The following is a description of a gene set: Genes whose promoters are bound by FOXP3 based an a ChIP-chip analysis. Mouse Gene Set: ZHENG_BOUND_BY_FOXP3 from publication Zheng Y, Josefowicz SZ, Kas A, Chu TT, Gavin MA, Rudensky AY (PMID 17237761) Transcription factor Foxp3 (forkhead box P3), restricted in its expression to a specialized regulatory CD4+ T-cell subset (T(R)) with a dedicated suppressor function, controls T(R) lineage development. In humans and mice, Foxp3 deficiency results in a paucity of T(R) cells and a fatal breach in immunological tolerance, causing highly aggressive multi-organ autoimmune pathology. Here, through genome-wide analysis combining chromatin immunoprecipitation with mouse genome tiling array profiling, we identify Foxp3 binding regions for approximately genes and for an intergenically encoded microRNA. We find that a large number of Foxp3-bound genes are up- or downregulated in Foxp3+ T cells, suggesting that Foxp3 acts as both a transcriptional activator and repressor. Foxp3-mediated regulation unique to the thymus affects, among others, genes encoding nuclear factors that control gene expression and chromatin remodelling. In contrast, Foxp3 target genes shared by the thymic and peripheral T(R) cells encode primarily plasma membrane proteins, as well as cell signalling proteins. Together, our studies suggest that distinct transcriptional sub-programmes implemented by Foxp3 establish T(R) lineage during differentiation and its proliferative and functional competence in the periphery. studied in species Mus musculus, and this is the list of marker genes: Kbtbd11, Psma1 (NCBI Gene Id 26440), Itpr2, Pgbd1, Actr3, 4930579G24Rik (RIKEN cDNA 4930579G24 gene), Rb1, Stat4, Rrm2, Nrip1, Rasa3, Psmd4, Cd44, St8sia4, Phxr4, Knl1, Llph, Pvt1, Pias2, Ptk2b, Zap70, Zfp874b, Syne2, Trib2, Znrf1, Zfp608, Usp6nl, Ms4a6c, Gm10688, Reep3, Cd226, Sdr16c5, Oprm1, Slc35b3, Arhgap25, Fermt1, Kdm3a, Ptger2, Rcsd1, Dusp6, Aggf1, Gata3, Rbl2, Sesn1, Gprin3, Vgll4, Btla, Arhgef3, Parp11, Hexim1, Wdr37, Gabrg1, Akap13, Mdm2, Ldlrad4, Bend6, Wdr45, Add3, Fam169b, D16Ertd472e (NCBI Gene Id 69342), Lars1, Klf3, Cnot6l, Eci2, Arl6, Churc1, Prkcq, Ssh2, Ptpn22, Lrch1, Etnk1, Nipbl, Ibtk, Mbnl1, Cnga1, Bcl6, Zfp36l2, Poli, Hk3, Rab8b, Enpp1, Gdi2, Gpd2, Pde7a, Map4k4, Hbs1l, Tlk1, Impa1, Zfp217, Zdhhc20 (zinc finger, DHHC domain containing 20), Mgat5, Ppp3cc, Tra2b (transformer 2 beta), Cast, Elf1, Cd96, Malt1, Samhd1, Slc23a2, St6gal1, Tmsb4x, Smap2, Man1a2 (NCBI Gene Id 99756), Rapgef2, 9330154K18Rik, Tbccd1, Zfp560, ENSMUSG00000122616, Tmco1, Slc35b4, Tox, Lrrc8c, Cep97, Ifi208, Phtf2 (putative homeodomain transcription factor 2), Osbpl8, Ablim1, Sell, Agpat5, Tmem252, Cdc42se2, Corin, Tgfbr2, Zfp715, Fam91a1, Satb1, Utrn, Atp8a2, Rad51c, Prdm1, Fasl, Wdr35, Taf8, St6galnac5, Cadps, Trav3-3, Rpl37, Rp9, Rap1a, Rfx3, ENSMUSG00000134755, Ankrd44, Cd200r1, P4ha1, Cd53, Gimap6, Tec, Scml4, Camk4, Cd69, Tg, Shtn1, Cdk19, Chd2, Ifngr1, Klf2, Clca1, Traf3ip3, Nfkbiz, Atp6-ps, Lrig1, Zc3h12d, Nsmce1, Adss2, Nsmaf, Frs2, Eps15l1, Hif1a, Agps, B3gnt2, Arid5b, Amph, Ptger4, Itga6, Zfp91, Rras2, Bzw2, Stk17b, Cx3cr1, Tmem67, Fyn, Flt3, Grk6, Gldn, 1700111E14Rik (RIKEN cDNA 1700111E14 gene), Ggta1, Abt1, Pag1, Trat1, Mrs2, E2f6, Apbb1ip, Slamf6, Map3k1, Gm10744, Sptbn1, Trp53inp1 (NCBI Gene Id 72576), Leprotl1, Timm8a2, S1pr1, Vcpkmt, Amot, Tnfsf11, Xcl1, Prrg4, Ubac2, Pym1, Ms4a4d, Morrbid, Gbp6, Pgap1, Glcci1, Hivep2, Ube2h, Il2ra, Samsn1, Btbd10, Ndc80, Trim27, Cnot2, Frmd4b, Ttc5, A130050O07Rik, Il10rb, Sp100, Vopp1, Rdm1, Nr4a2, Esyt2, Utp3, Klf6, Sumf1, Cadm3, Rgs13, Trim12a, Muc20, Dipk1a, Rnf125, Ankrd11, Usp3, Xxylt1, Gm6899, Axl, Trib1, Herpud2 (NCBI Gene Id 80517), Cr1l, Slc30a7, Cdkn1b, Rhoh, Lta4h, Ulk4, Rabgap1l (RAB GTPase activating protein 1-like), Tube1, mt-Nd4l, Akr1d1, AA467197, Exoc6b, Hjv, Prag1, 9930111J21Rik2, Zfp51, Fas, Gpr18 (NCBI Gene Id 263515), Ttc39b, Cdh10, Mllt3, Scn8a, Gpr65, Fam107b, Man1a, Zc3hav1, Stat5b, Nck2, Il7r, Adam19, 3300002I08Rik, C2cd5, Dennd6a, Rgs10, Nrp1, Ank, Banp, Jak1, Otulinl, Fem1c, Nr2e3, Nus1, Thada, Spp1, Psrc1, Lrrc66, Tespa1, Lef1, Top2b, Mamdc2, Socs2, Ikzf2, Jarid2, Dennd5a, St8sia1, Ifi214, Vwf, Ets1, Mrtfa, Anxa1 (annexin A1), Itm2b, 1700041G16Rik, Cipc, Col11a1, Crem, Ifi209, Inpp4b, Ica1, Irf2, Kdsr, Eola1, Exoc2, Tent5c, Ift80, Vps37b, Ncoa3, Usf3, Spg7, Arl4a, Snca, P2ry10, Or2v1, Nup153, Ankrd28, Fam76b, Ptger3, Sbspon, Zbtb1, Cpe, Nek7, Lnx2, 2010109A12Rik, Sgce, Pebp4, Fyb1, Arhgap5, Ctla4, Epb41, Gimap1, Ms4a4c, Hectd1, Enpp6, Gvin2, L3mbtl3, Prkch, Sh2d1a, Cdk17, Cd200, Selp, Kat6b, Fbln5, Themis, Zbtb25, Smad3, Tlr6, Rcbtb2, Macf1, Gng2, Ms4a6b, Ifng, Bcl11b, Pip4k2a, Herc3, Cobll1, Nsmce2, Elk3 (ELK3, member of ETS oncogene family), Dock10, Gm4956, Tcf12, Nr4a3, Asxl1, Gpr183, Gphn, Vps54, Cited2, Tmem64, Mrpl39, Bicdl1, Tnfaip3, Zbtb2, Ust, Tnrc6b, Mdfic, Dtx4, Ms4a4b, Ccr7, Srpk1 (serine/arginine-rich protein specific kinase 1), Map3k5, Zfp874a, Atp1b3, Cacnb4, Parp8, Fli1, Gtdc1, Celf2, 4930453N24Rik, Nox3, Tbc1d15, Idh1, Pik3cg (NCBI Gene Id 76039), Il6st, Ubash3b, Atxn7, A630001O12Rik, Tasp1, Ppp2r5c, Rapgef6, Dapl1, Zbtb20 (zinc finger and BTB domain containing 20), Snx9, Foxp1, Cpox, Cradd, Gm5796, Aqr, Obi1, Peli1, Nudcd3, Mynn, Chd7, Ifnar2, Aim2, Gimap4, Prkar2b, Enox1, Lats2, Cmah, Ift57, Cc2d2a, Grb14, Asxl2 (NCBI Gene Id 75302), Ext1, Tbc1d5, Ifit3, Parm1, Evi5, Fam3c, Tspan13, Ints9, Ms4a7, Ago2, Park7, Map3k8, Gimap9, Eef1e1, Nt5e (NCBI Gene Id 74242), Pde4b, Gm11529, Cblb, Cd28, Rgs1, Heatr5a, Xpo4, Nr5a2, Lcp1, Jmjd1c, Arhgef10, Sag (NCBI Gene Id 20215), Nt5c3, Adamts6, Ptprc, Tbc1d4, Atp6v1g3, Spef2, Wipf1, Hmg20a, Trim59, Etv3, Tpp2, Tlr8, Abtb2, Ccdc198, Clec2d, Nsd3, Tbc1d30, Ankrd55, Ahr, A930002I21Rik, Ninj2 (NCBI Gene Id 29862), Tmem71, Sh3kbp1, Atp2b1, Elmo1, Rbl1 (NCBI Gene Id 99395), Gria3, Ppp1r3f, Ifit3b, Dynlt5, D6Wsu163e, Tmem222, Gatb, Trav12-1, Zpbp2, Cyth1, Rmi2, Sgms1, Lsm5, Irf4, Arhgap15, Plcg1 (NCBI Gene Id 99130), Ptbp3, Rbbp6, Ptprk, Icos, Dad1, Rab3ip, Ndufv2, Tet3, Spmip7, Zfand6, Bcl2, Sik3, Snx14, Slamf1, Stk10, Urm1, Cytip, Cwc27, Rab19, F2rl1, Stk24, P2ry10b